Given this list of marker genes ZC3H3, ACVR1B, ACVR2B, ACVR2A, CSNK2B, FGF9, here is a description of the gene set: Any process that activates or increases the frequency, rate or extent of the activity of any activin receptor signaling pathway. Human Gene Set: GOBP_POSITIVE_REGULATION_OF_ACTIVIN_RECEPTOR_SIGNALING_PATHWAY species: Homo sapiens